The following is a description of a gene set: Mouse Gene Set: GOMF_DNA_BINDING_DOMAIN_BINDING species: Mus musculus Binding to a protein's DNA binding domain (DBD)., and this is the list of marker genes: Rxra, Psmc3ip, Atxn2, Prox1, Pparg, Armc10